Given this list of marker genes Zfand2b, Pax3, Prkag3 (NCBI Gene Id 241113), Gm29065, Farsb, Tuba4a, Fev, Kcne4, Gm5830, Inha, Cryba2, Gm15180, Asic4, Gm29539, Gm29536, Gm28410, Stk11ip (NCBI Gene Id 98742), Mir6343, Abcb6, Epha4, 5730419F03Rik, Gm15183, Gmppa, Ptprn, Gm24160, Cdk5r2, Gm10555, Slc4a3, Obsl1, Gm26263 (predicted gene, 26263), Chpf, 4833412K13Rik, Gm816, Gm29611, Gm5257, Ankzf1, A630095N17Rik, Ttll4, Dnajb2, Mogat1, Nhej1, Ap1s3, Slc23a3, Wnt6, Des, Mrpl44 (mitochondrial ribosomal protein L44), Speg, Gm16582 (NCBI Gene Id 102634844), Resp18, Gm19027, Stk16, Gm15179, Gm28071, Serpine2, Cfap65, Acsl3, Atg9a, Wnt10a, Dnpep, Retreg2, BC035947, Mir375 (microRNA 375), Cnppd1, Tmem198, Sgpp2, Cyp27a1, Utp14b, Glb1l, Ihh, Wdfy1, Gm2102, Gm5529, Gm17751, Scg2, Gm6159, Mir6352, here is a description of the gene set: species: Mus musculus Mouse Gene Set: chr1C4